Given this list of marker genes FOXG1, AGO3, AURKB, NCOR1, PRKACA, AGO1, NCOR2, CREB1, SIN3A, AGO4, TBL1XR1, CALM1, MOV10, GPS2, CAMK2A, MECP2, LBR, TNRC6C, HDAC2, TNRC6A, AGO2, HDAC3, TBL1X, TNRC6B, CAMK2B, CAMK4, CAMK2D (calcium/calmodulin dependent protein kinase II delta), HTT, HIPK2, HDAC1, MIR132, CAMK2G, here is a description of the gene set: Transcription of the MECP2 gene is known to be regulated by methylation of the promoter and the first intron, but the responsible methyltransferases are not known.<p>Translation of MECP2 mRNA is negatively regulated by the microRNA miR-132. Transcription of miR-132 is regulated by BDNF signaling, through an unknown mechanism.<p>Binding of MECP2 to other proteins and to DNA is regulated by posttranslational modifications, of which phosphorylation has been best studied. Calcium dependent protein kinases, PKA and CaMK IV, activated by neuronal membrane depolarization, phosphorylate MECP2 at threonine residue T308 (corresponding to T320 in the longer MECP2 splicing isoform, MECP2_e1). Phosphorylation at T308 correlates with neuronal activity and inhibits binding of MECP2 to the nuclear receptor co-repressor complex (NCoR/SMRT). In resting neurons, MECP2 is phosphorylated at serine residue S80, which results in a decreased association of MECP2 with chromatin. Nuclear serine/threonine protein kinase HIPK2 phosphorylates MECP2 on serine residue S80. In activity-induced neurons, upon neuronal membrane depolarization, MECP2 S80 becomes dephosphorylated, and MECP2 acquires phosphorylation on serine S423 (corresponding to mouse Mecp2 serine S421). CaMK IV is one of the kinases that can phosphorylate MECP2 on S423. Phosphorylation of MECP2 at S423 increases MECP2 binding to chromatin. AURKB phosphorylates MECP2 at serine residue S423 in dividing adult neuronal progenitor cells.<p>Besides binding to the NCoR/SMRT co-repressor complex, MECP2 binds the SIN3A co-repressor complex. This interaction involves the transcriptional repressor domain of MECP2 and the amino terminal part of the HDAC interaction domain (HID) of SIN3A. HDAC1 and HDAC2 are part of the SIN3A co-repressor complex that co-immunoprecipitates with MECP2. While binding of MECP2 to SIN3A at target genes is associated with transcriptional repression, binding to CREB1 at target genes is associated with transcriptional activation. Function of MECP2 can be affected by binding to FOXG1, another gene mutated in Rett syndrome besides MECP2 and CDKL5, and HTT (Huntingtin). The subnuclear localization of MECP2 may be affected by binding to the Lamin B receptor (LBR). part of: Transcriptional Regulation by MECP2 Reactome Pathway: Regulation of MECP2 expression and activity species: Homo sapiens